Given this list of marker genes Borcs5, Stk11, Map2, Trim46, Mecp2, Cnih2, here is a description of the gene set: species: Mus musculus Mouse Gene Set: GOBP_REGULATION_OF_VESICLE_TRANSPORT_ALONG_MICROTUBULE Any process that modulates the frequency, rate or extent of vesicle transport along microtubule.